The following is a description of a gene set: Any process that modulates the rate or extent of gastrulation. Gastrulation is the complex and coordinated series of cellular movements that occurs at the end of cleavage during embryonic development of most animals. species: Homo sapiens Human Gene Set: GOBP_REGULATION_OF_GASTRULATION, and this is the list of marker genes: POGLUT1, TENM4, TGIF2, OSR1, NODAL, LHX1, SCX, HNF4A, FOXA2, RACK1, CRB2, OTX2, TGIF1 (NCBI Gene Id 91941)